The following is a description of a gene set: We have previously shown that rheumatoid factors (RF) produced by Fas-deficient autoimmune-prone mice typically bind autologous IgG2a with remarkably low affinity. Nevertheless, B cells representative of this RF population proliferate vigorously in response IgG2a/chromatin immune complexes through a mechanism dependent on the sequential engagement of the BCR and Toll-like receptor 9 (TLR9). To more precisely address the role of both receptors in this response, we analyzed the signaling pathways activated in AM14 B cells stimulated with these complexes. We found that the BCR not only serves to direct the chromatin complex to an internal compartment where it can engage TLR9 but also transmits a suboptimal signal that in combination with the signals emanating from TLR9 leads to NF-kappa-B activation and proliferation. Importantly, engagement of both receptors leads to the upregulation of a group of gene products, not induced by the BCR or TLR9 alone, that include IL-2. These data indicate that autoreactive B cells, stimulated by a combination of BCR and TLR9 ligands, acquire functional properties that may contribute to the activation of additional cells involved in the autoimmune disease process. Human Gene Set: GSE6674_UNSTIM_VS_ANTI_IGM_STIM_BCELL_UP species: Homo sapiens Genes up-regulated in B lymphocytes: control versus anti IgM. from publication Busconi L, Bauer JW, Tumang JR, Laws A, Perkins-Mesires K, Tabor AS, Lau C, Corley RB, Rothstein TL, Lund FE, Behrens TW, Marshak-Rothstein A (PMID 18025183), and this is the list of marker genes: PSMD5, COX17, DTYMK, N4BP2L2, GALM, RHOC, USP16, NSF, RNPC3, RAB35, RASA1 (RAS p21 protein activator 1), HARBI1, ST3GAL3 (NCBI Gene Id 6487), CAPN11, NUF2, GNPDA2, ITGB2, EEF1AKMT2, CYP20A1, IL6ST, SCFD2, DYNLL2, TIFAB, PLAA, SLF1, YLPM1, PTPN11, PTGR2 (NCBI Gene Id 145482), DCBLD2, GRK5, HSP90AB1, FTO, SEMA7A, HERC3, XBP1, ST7, NAIF1, DMAC2, PON2, COPS4, MED28, GTF2H1, TRAM1, IL27RA, ENTPD6, ASB7, ERMP1, BMAL1 (NCBI Gene Id 406), GRK4 (NCBI Gene Id 2868), ATP11C, TRPV2, APOC2, CALCRL, ZFAND5, MIR450B, ARHGAP15, SMC6, FERMT3, AP1S2, LPL, USP6NL, ACTR5, NONO, SCD, CCNT1, NOL7, SLC39A11, POLR2F, NCKAP1, MFSD14B, ZMPSTE24, NEK4, GAA, NDUFB8, DENND6A, LRP10, CEP83, NCOA7, TTC13, NOL10, PTK2, GTPBP8, POGLUT1, TLE6, ZDHHC13, SNAP29, SEC63, ATL3, TBC1D22A, C1QC, MRPL17, COPB2, GINM1, RBBP8, ACER3 (alkaline ceramidase 3), PIGP, ATG4C, PRKAB2, GOLIM4, CDC16, MPZL2, ARHGAP18, NPTN, PRKCA, AOC1, MCRIP1, CYRIA, SMYD5, TMEM106B, MRPS18A, FAR1, RSU1, TAX1BP1, GOLGA1, FLVCR1, USP2, KRCC1, IRAK4, ECD, TM7SF3, TPK1, FBXO28, PARP1, CPOX, TFAM, SLC38A9, OTUD5, PDCD1LG2, DEK, SLC4A1AP, PDAP1, PIK3IP1, CERS5, SMU1, CLTB, AP2S1, MIA3, EPHX1 (NCBI Gene Id 2052), ALDH6A1, WRN, MMGT1, TTC32, ZCCHC10, FN3KRP, HEXB, SLC25A24, COX16, NOC3L, ITSN1, NPAT, SNX2 (sorting nexin 2), FUBP1, KIZ, UBA5, HOOK1, PAFAH1B2, ALG3, NR4A3, SBNO1, VHL, POLR3G, AHCYL1